Given this list of marker genes ESPL1, GPD2, SLC4A5, DZIP1, STK26, NXF1, PPEF2, PDLIM1, LGALS3, ESRP1, RNF170, RASGRP2, GNG11, GRIP1, PIK3IP1, DHH, AEBP1, PEG3, EGF, SF3B2, FAM120AOS, LPAR6, SEMA4A, IFNG, SMIM3, PIM2, MICAL2, FASLG, GAS6, STT3B, AR, SESN3, NUP160, SMOX, POLA1, OLR1, ERO1B, GPR18, ECE1 (endothelin converting enzyme 1), PITPNC1, CD163, GUCA1B, RASSF2, PXYLP1, NFE2L2, KLHL7, RNF19A, LAX1, ARHGAP17, PPM1K, NACC2, MGAT3, PLCXD3, CD160, SLC49A4, CUX2, MOSMO, PARP3, SKP2, RINL, ANGPTL6, COMMD8 (COMM domain containing 8), ANKMY2, EFS, SPATS1, WT1, THEMIS2, CERS6, ALDH7A1, RAB3IP, TMEM176B, DNAJC3, MBD4, ACP3, FAP, IL6R, HLA-A (major histocompatibility complex, class I, A), RPL13, IGFBP4, RALGPS2, BLK, HECTD3, SNAI3, SGK3, IL17RE, MID1IP1, KLHDC1, PLPP3, RNF13, CFAP107, EDNRA, NME4, GFOD2, NKG7, CSNK1E, MYCBP2, SFI1, TMIE, DDA1, NKX3-2, IL4, RAB3GAP1, TMPRSS11D, ANO4, SPMIP6, DGKE (NCBI Gene Id 8526), TTC3, GPATCH2L, CYP1B1, PPP3CB, CCR6, TWF2, BLM, CNGA1, TRIOBP (NCBI Gene Id 23712), DIPK2A, GNGT2, MYLIP, SLC39A6, ANLN, SPIRE2, B4GALNT2, ZNF354A, IL12RB2, TMTC4, ATP8B4, MGAT4A, LEF1, MLLT11, SLAMF7, PDE11A, VSNL1, PHF24, IL21, TDRP, PER3, CD4, SCRN3, PAG1, ADGRG3, HPS3, BTG2, NUB1, ADH1C, LRGUK, ZFP82, CCDC62 (NCBI Gene Id 84660), DMAC2L, RAP1GAP2, ACSS1, GPX2, SGMS1, OVGP1, SLC16A10, SGPP1 (NCBI Gene Id 81537), CCDC82, FAM78A, GPBP1L1, MECR, RFLNB, TRUB1, ADO, ABCB1, EVI2A, CIC, ENC1, GMFG, NMT1, RAD51AP1, CD40LG, ASB13, B3GALT5, PARP8, DOCK5, ARSB, RNF19B, IL2, ANKRD6, PLCB4, CASP4, DIPK1A, TBC1D24, EHD3, DENND2D, RAI14, CDH20, DENND4C, PPP1R10, FAM171B, GCLC, LRP12, DACT3, TNFSF14, XKRX, SPR, NEDD9, MYO6, SOAT2, SMUG1, EZH1, here is a description of the gene set: studied in species Homo sapiens from publication Feuerer M, Hill JA, Kretschmer K, von Boehmer H, Mathis D, Benoist C (PMID 20231436) Genes down-regulated in comparison of TregCD103-Klrg1 versus TconvLP (see Table 1S in the paper for details). Human Gene Set: GSE20366_TREG_VS_TCONV_DN Regulatory T (Treg) cells that express the FoxP3 transcription factor are essential for lymphoid homeostasis and immune tolerance to self. Other non-immunological functions of Treg cells, such as controlling metabolic function in adipose tissue, are also emerging. Treg cells originate primarily in the thymus, but can also be elicited from conventional T cells by in vivo exposure to low-dose antigen or homeostatic expansion, or by activation in the presence of TGFβ in vitro. Treg cells are characterized by a distinct transcriptional signature controlled in part, but not solely, by FoxP3. For a better perspective on transcriptional control in Treg cells, we compared gene expression profiles of a broad panel of Treg cells from various origins or anatomical locations. Treg cells generated by different means form different sub-phenotypes identifiable by particular combinations of transcripts, none of which fully encompass the entire Treg signature. Molecules involved in Treg effector function, chemokine receptors, and the transcription factors that control them are differentially represented in these subphenotypes. Treg cells from the gut proved dissimilar to cells elicited by exposure to TGFβ, but instead they resembled a CD103+Klrg1+ subphenotype preferentially generated in response to lymphopenia.